Given this list of marker genes ACSL6, ACSM5, ACSF3, ACSM4, SLC27A4, AACS, SLC27A5, ACSBG2, ACSM3, DIP2A, ACSM2B, ACSM1, ACSF2, SLC27A1, ACSL5, ACSS3, ACSS1, SLC27A2, ACSM6, SLC27A6, ACSBG1, SLC27A3, ACSM2A, ACSL3, ACSL1, ACSL4, ACSS2, here is a description of the gene set: species: Homo sapiens Catalysis of the reaction: substrate + ATP + CoASH = AMP + diphosphate + substrate-CoA. Human Gene Set: GOMF_COA_LIGASE_ACTIVITY